Given this list of marker genes ITGA8, NPNT, GREM1, PAX2 (paired box 2), SALL1, GFRA1, SIX1, SLIT2, HOXD11, WNT11, RET, GDNF, ROBO2, EYA1, BMP4, HOXC11, FOXC2, FOXC1, SIX2, HOXA11, ITGB1, here is a description of the gene set: studied in species Homo sapiens Human Gene Set: REACTOME_FORMATION_OF_THE_URETERIC_BUD Formation of the ureteric bud